Given this list of marker genes NSD1, ETS2-AS1, PPFIA1, STAT6, AGPAT3, PCGF3, LINC02564 (NCBI Gene Id 124908006), here is a description of the gene set: Genes containing one or more binding sites for (NEUROD2) in their promoter regions (TSS -1000,+100 bp) as identified by GTRD version 20.06 ChIP-seq harmonization. studied in species Homo sapiens Human Gene Set: NEUROD2_TARGET_GENES from publication Yevshin I, Sharipov R, Kolmykov S, Kondrakhin Y, Kolpakov F (PMID 30445619)